The following is a description of a gene set: Human Gene Set: REACTOME_NETRIN_1_SIGNALING species: Homo sapiens Netrin-1 signaling, and this is the list of marker genes: ABLIM2, SIAH1, DSCAML1, ROBO1, ABLIM3, TRPC4, NCK1, UNC5D, PLCG1, PITPNA, SLIT1, TRPC7, WASL, UNC5B, RGMA, ABLIM1, RGMB, TRPC6, FYN, SLIT3, DSCAM, SLIT2, HJV, EZR, PTPN11, NTN4 (netrin 4), TRPC5 (NCBI Gene Id 7224), SRC, CDC42, TRPC3, NEO1, PTK2, RAC1, TRPC1, UNC5C (unc-5 netrin receptor C), MYO10, NTN1, DCC, TRIO, UNC5A, DOCK1, SIAH2, AGAP2 (NCBI Gene Id 9809), PRKCQ